The following is a description of a gene set: Genes up-regulated in comparison of naive CD8 T cells treated with IL7 versus those treated with IL4 and IL7. Effects of IL-4 on CD8 T cells functions are largely unknown. IL-4 induces survival and proliferation of CD8 T cells, but several studies suggest that IL-4 could also affect several functions of CD8 T cells such as cytotoxicity. Our team has shown that IL-4 repress the expression of Ccl5 in vitro. To define more precisely the impact of IL-4 on CD8 T cells, we performed a whole genome expression microarray analysis of naive and memory CD8 T cells cultured in presence or absence of IL-4. This approach allowed us to define the IL4-gene-expression signature on CD8 T cells. Human Gene Set: GSE32423_IL7_VS_IL7_IL4_NAIVE_CD8_TCELL_UP studied in species Homo sapiens from publication Ventre E, Brinza L, Schicklin S, Mafille J, Coupet CA, Marçais A, Djebali S, Jubin V, Walzer T, Marvel J (PMID 22942430), and this is the list of marker genes: SLC47A1, CCDC191, PRM2, ST3GAL1, SDR16C5, S100B, POLR1B, FARP1, OR7C1, CYP2E1, ZC3H15, PUS1, HIC1 (NCBI Gene Id 3090), NINJ1, TRIM45, GIT1, CTSK, SLCO4A1, PDE1A (NCBI Gene Id 5136), NKX2-5, SLFNL1, CDC25B, FOXP3, IPCEF1, PCSK4, RDH16, PWP2, PLCB3, JAKMIP2 (NCBI Gene Id 9832), C3AR1, NIPSNAP3B, MAP7D1, H1-4, VAT1, KLF17, TBC1D25, ELOVL6, CHRM4, CD84, B3GNT5, RUNX3, PRSS42P, KCNE4, TBX20, FSTL3, ST8SIA1, TPTE (transmembrane phosphatase with tensin homology), OSGIN1, TCF7L1, MBOAT1, ARHGEF40, FAAP20 (NCBI Gene Id 199990), IMPDH2, TUSC1, SIRPA, GPR88, BCL2L2, CXCL12, RALBP1, TLX2, NOS3, ANGPTL4, MAS1, PPARA, BIN1, ABCB11, GPR22, ATP8B4, PACC1, IRAK3, CXorf58, FAM241A, STK33, TSR1, ANGPTL7, RNF186, GLI3, FAH, ST6GALNAC5, KRT23, C1orf54, METTL13, DHRS11, KAT2A, AVEN, ACVR1, CYSLTR1, NUCB2, IL24, DNAAF4, PASK, RIN2, AMIGO2, GTF3A, CYSRT1, LFNG, WNK4, RGS11, PDGFRA, TGM3, PABPN1, GLIS1, PLAG1, PLSCR4, TNNT3, P2RY13, LRRC75B (NCBI Gene Id 388886), CHRNA7, PXYLP1, OR11H4, MIA2, DHDH, DTX1, PRRT3, CAPN6, CCDC85A, CAPS2, ADAMDEC1, ATP10A, ZFP42, SLC25A18, LANCL1, PAXX, LAMTOR1, KDELR3, AKR1C3, ZNF518B, ZNF786, BABAM1, OTOS, NCCRP1, ADGRG3, EML1, BCKDHB, CXXC5, ETV4, GATAD2A, CC2D1B, RECK, GGT1, CHD3, UBALD1, SORCS2, CD163, TP53TG5, ZBTB11-AS1, IGSF8, SELENOW, ASPG, TNF, DAG1, SLC8A2, PRDX6, TMEM130, NRK, KRT25, ZCCHC13, ABCB9, TBL2, MROH2B, RAI14, AMER3, LRRC19, CXCL3, MDN1, BTNL2, GNAT1, RERG, NSUN2, OSBPL5, ADAMTSL4 (ADAMTS like 4), PHYHIP, TTC36, SUSD5, SEC14L5, WDR64, HEBP1, DNMT3B, ABHD14B, GART, COL3A1, TMEM31, RIOX2, BDH2, KRTAP26-1, AANAT, AOC1, ATN1, PMM1, LDHB, DLX5, TBC1D5, FZD7, TYROBP, RAX, NOS2, LURAP1L, COLGALT1, EIF4G1